Given this list of marker genes UGT2A3, CXCL10, HCK, SLC17A1, CCL7, RTP4, OTOR, FPR2 (formyl peptide receptor 2), RNF114 (NCBI Gene Id 55905), PARP9, TXNDC8, IDO1, PSMB8, IFI35, SHISA5, C2, HLA-E, OAS1, KRT84 (keratin 84), FCGR3A, SLC6A16, ERICH3, OTP, IRGM, PML, COL4A3, SAMD9L, CMTR1, APOD, CALHM6, MMP20, TERB2, MAP2K1, LY6E, ZGLP1, SP8 (NCBI Gene Id 378050), SLC30A8, HELZ2, NEUROD4, PKHD1L1, GZMB, AIDA, PIK3AP1, GNB4, OOSP2, NOD1, ZBTB26, UBA7 (NCBI Gene Id 7875), SASS6, SAMHD1, ZNF563, IL15, PARP14, NMI, SP110, SUSD4, SGK2, BMP5, B2M (NCBI Gene Id 567), IRF7, IFIT1B, AREL1, DTX3L, GTPBP8, ZUP1, CD69, KAZN, SYTL3, RNF213, IRF1, CETN1, DDX4, NECAB1, PARP11, DHX58, IFIH1, MARCHF5, USB1, CLIC4, IFIT1, MTHFR, OXGR1, LAMP2 (lysosomal associated membrane protein 2), FCGR1A, PARP12, CXCL11, TRIM5, ADAR, RAB9B, GABRA1 (NCBI Gene Id 2554), IL18BP, UBXN10, CD274, IFI44, SECTM1, PABPC5, RYR2, GATA1, KCNJ1, RIGI, FGF12, TNFRSF11A, DAXX, TAP1, NKG7, CXCL9, PSMB9, IFIT3, RAB19, DACH1, FGL2, CFI, TNFSF10 (TNF superfamily member 10), HERC6, APOBEC3B, KLRK1, CCL13, HLA-G, OASL (NCBI Gene Id 8638), OLFM4, XAF1, STAT1, ZBP1, THEMIS2, SLFN5, CH25H, PSME1, GBP6, C5orf47, NPC2 (NCBI Gene Id 10577), RSAD2, ISG15, OR11H4, EIF2AK2 (NCBI Gene Id 5610), OAS2, MX1, MPEG1, MAGEB16, STAT2, TRIM21, UPP1, ARF4, TNNC1, SETDB2, CHRM1 (cholinergic receptor muscarinic 1), CD200R1L, CSN2, PNP, ANKRD63, SNX10, NXPH2, TRIM34, ETNK1, GBP4, KAT6A, TMEM217, TDO2, PSMB10, TLR3, CITED1, IFIT2, CST5, TENM1, UBE2L6, CMPK2, IFITM3, SYCP1, INPP1, SLAMF8, OAS3, USP18, SLC5A11 (NCBI Gene Id 115584), GBP7, HECTD2, FANCA, CDH7, OTUD7A (NCBI Gene Id 161725), ZNFX1, WARS1, FPR1, LYZL1, IL10, MX2, ISG20, CD40, SLFN13, IRF9, CLCA4, IFI44L, SFMBT2, ZP2, BATF2, DACH2, FOXA1, DCK, SERPINB9, GBP2, RNASE6, GCH1, IDNK, here is a description of the gene set: Human Gene Set: GSE19888_ADENOSINE_A3R_INH_VS_ACT_WITH_INHIBITOR_PRETREATMENT_IN_MAST_CELL_UP We demonstrate that the G protein Gi3 is the cellular target of the adenosine A3 receptor (A3R). By using a cell permeable peptide comprising the C-terminal end of Gαi3 fused to an importation sequence (ALL1) as a selective inhibitor of Gi3 signaling, we show that by coupling to Gi3, the A3R stimulates multiple signaling pathways in human mast cells, leading to upregulation of cytokines, chemokines and growth factors.Following contact with activated T cell membranes, endogenous adenosine binds to and activates the A3R, resulting in Gi3-mediated signaling. Specifically, the majority of ERK1/2 signaling initiated by contact with activated T cell membranes, is mediated by Gi3, giving rise to ALL1-inhibitable cellular responses. These results unveil the physiological GPCR that couples to Gi3 and establish the important role played by this G-protein in inflammatory conditions that involve adenosine-activated mast cells. We used microarrays to detail the effect of ALL1 on gene expression of HMC-1 cells activated directly by the A3 receptor, or by contact with activated T cell membranes. from publication Baram D, Dekel O, Mekori YA, Sagi-Eisenberg R (PMID 20190146) Genes up-regulated in HMC-1 (mast leukemia) cells incubated the peptide ALL1 versus those followed by treatment with Cl-IB-MECA. species: Homo sapiens